The following is a description of a gene set: studied in species Mus musculus This event has been computationally inferred from an event that has been demonstrated in another species.<p>The inference is based on the homology mapping from PANTHER. Briefly, reactions for which all involved PhysicalEntities (in input, output and catalyst) have a mapped orthologue/paralogue (for complexes at least 75% of components must have a mapping) are inferred to the other species. part of: SWI/SNF chromatin remodelers Reactome Pathway: Formation of neuronal progenitor and neuronal BAF (npBAF and nBAF) electronically inferred by orthology from the curated human pathway, and this is the list of marker genes: Smarcd1, Smarca2, Smarcc1, Ss18, Smarca4, Bcl7b, Bcl7a, Arid1a, Smarcb1, Phf10, Smarcd2, Smarcc2